The following is a description of a gene set: Human Gene Set: GSE22432_MULTIPOTENT_VS_COMMON_DC_PROGENITOR_DN Genes down-regulated in amplified: multipotent progenitors versus common dendritic cell progenitors. studied in species Homo sapiens Dendritic cells (DCs) in lymphoid tissue comprise conventional DCs (cDCs) and plasmacytoid DCs (pDCs) that develop from common DC progenitors (CDPs). CDPs are Flt3+c-kitintM-CSFR+ and reside in bone marrow. Here we describe a two-step culture system that recapitulates DC development from c-kithiFlt3-/lo multipotent progenitors (MPPs) into CDPs and further into cDC and pDC subsets. MPPs and CDPs are amplified in vitro with Flt3 ligand, stem cell factor, hyper-IL-6 and insulin- like growth factor-1. The four-factor cocktail readily induces self-renewal of MPPs and their progression into CDPs and has no self-renewal activity on CDPs. The amplified CDPs respond to all known DC poietins and generate all lymphoid tissue DCs in vivo and in vitro. Additionally, in vitro CDPs recapitulate the cell surface marker and gene expression profile of in vivo CDPs and possess a DC-primed transcription profile. Transforming growth factor-β1 (TGF-β1) impacts on CDPs and directs their differentiation towards cDCs. Genome-wide gene expression profiling of TGF-β1-induced genes identified transcription factors, such as interferon regulatory factor-4 (IRF-4) and RelB, that are implicated as instructive factors for cDC subset specification. TGF-β1 also induced the transcription factor inhibitor of differentiation/DNA binding 2 (Id2) that suppresses pDC development. Thus, TGF-β1 directs CDP differentiation into cDC by inducing both cDC instructive factors and pDC inhibitory factors. from publication Felker P, Seré K, Lin Q, Becker C, Hristov M, Hieronymus T, Zenke M (PMID 20881193), and this is the list of marker genes: NUAK2, TBC1D17, DHTKD1, PPCDC, PPP2R5A, WNK2, GYPC, ARMCX6, STAT1, UBC, KCNV1, GPC1 (glypican 1), PSMA4, PANK2 (pantothenate kinase 2), TAX1BP1, ATP8A2, SCARB2, HIF1A, TSPAN1, PLEKHM2, ASB6, ST14, CASP3, EPHA6 (EPH receptor A6), ADPRH (NCBI Gene Id 141), MAP4K2, USP18, COA5, BBX, ELL3, BOLL, SELENOW, EFCAB12, UTY, ADD2, RBMS2, TPD52L1, DCBLD2, MTUS1, PLEKHH1, SMPDL3B, MINPP1, KATNB1, BCKDHB, BMPER, CCT8L2, RBM43, ARHGEF3, TSPAN11, IQGAP2, SLC6A6, FBXL15, NEK7, ZC3H10, FANCA, TMEM67, LRP10, NPC2, ZNF260, BICRA, ACACB, TAP2, GRINA (glutamate ionotropic receptor NMDA type subunit associated protein 1), CXCR6, DBNL, CNP, SPTLC2, MAPKAP1, PLCL2, IL13RA2, FBXO7, TNFSF10, R3HCC1L, ZBTB10, PBLD, CRYL1, ACOX3, HLTF, SASS6, RPE, MFSD1, KRTAP4-7, SLFN12, HSPA4L, ST6GALNAC4, INTS9, AMN1, PRSS58, ACADL, AHI1, ADAM33, CELA3B, BST2, HERC6, SELENOM, PRSS23, UBE2Z, MEN1, MISP, FBXO32, HOMER1, COL4A2, TMOD3, KIF9, RALA, PSME1, EXOC7, RNF31, PNMA8A, SRPX, GTPBP1, DDX6, FNDC1, SLAMF6, DENND1A, LMBRD1, IRF7, MICU2, TMPRSS15, GAB2, STX8, RGL1, ZNF473, BFAR, LDLRAD4, UBL7 (ubiquitin like 7), PIK3CB, TNFSF8, RAB9A, FAM193B, USB1, CLVS2, CPNE3, PTCRA, SUDS3, AP2B1, CLEC4E, RAB19, HMGN3, LY86, LYRM1 (NCBI Gene Id 57149), UBTFL1, CD180, TSPAN13, BTG4, TRPM1, KCNS2, APMAP, BRI3, CD86, SLC7A8, PER1, PARP8, SNRNP35, ZPR1, TET3, ZBTB24, CENPL, PER2, RIGI, CLCN7, DGKA, SLC35F6, SLAMF9, PTPN6, UBTD1, ZMYND12, FXYD2, TSPO, TLR3, USP8, B4GALT5, PRKD2, SOCS1, TTC1, CSNK1D, LEPROTL1, RNF4, CFAP126, PIK3CD, NUDT13, TMEM51, ABCB1, TFG, CA13 (carbonic anhydrase 13), ROBO3, PRDX2, HGD, RNF114, ZBTB2, SLAMF8, ATF3, SLC28A2, COG4, ALKBH4, JAK1, IL12RB2, PML, INSM2, STX4